Given this list of marker genes AMOT, PTK2B, BCAR1, NOS3, MIR499A, AKT1, SEMA5A (NCBI Gene Id 9037), NFE2L2, FGFR1, PIK3CB, WNT5A, AAMP, ANGPT4, P2RX4, STAT5A, FGF1, MIR146A, SIRT1, EMC10, MIR10A, TMSB4X, MIR150, FGF16, FOXP1, GAB1, ROCK2, EDN1, KDR, TEK, RHOJ, PRKD1, MIR199A1, FGFBP1, PLG, GPI, RIN2, MIR210, MAP2K3, MIR126, ETS1, PRKCA, ANGPT1, GATA3, VEGFC, FUT1, ITGB3, MIR143, JCAD, ANXA1, PLCG1, BSG, GPLD1, ZC3H12A, AGT, MET, ADGRA2, MIR939, NRP2 (neuropilin 2), FGF18, NRP1, MIR10B, MIR27B, MIR342, PDPK1, HDAC9, HMOX1, PRKD2, PLK2, PLPP3, PDCD6, SASH1, TMEM201, PIK3CG, TGFB1, MIR296, SMOC2 (SPARC related modular calcium binding 2), PROX1, ADAM17, LCN2, GRN, SCARB1, CALR, EGF, CD40, CCBE1, FOXC2, MIR21, MIR30A, MIR200A, HIF1A, SPARC, ITGB1BP1, TGFBR3, HSPB1, ATP5F1B, GFUS, FLT4, HMGB1, RAC1, ABL1, GREM1, THBS1, MIR27A, VEGFA, MIR23A, MIR132, MIR1908 (NCBI Gene Id 100302263), AKT3 (NCBI Gene Id 26068), CIB1, ATP5F1A, MIRLET7F1, PTGS2, PIK3C2A (phosphatidylinositol-4-phosphate 3-kinase catalytic subunit type 2 alpha), PIK3CD, BCAS3, ZNF580 (zinc finger protein 580), PDGFB, ATOH8, RHOB, SRPX2, LGMN, MAPK14, WNT7A, HDAC7, MIR31, MIR221, MIR101-1, MIR29A, MIR135B (NCBI Gene Id 442891), RRAS, MIR487B, SP1, GATA2 (GATA binding protein 2), ANXA3, FGF2, CRIPTO (NCBI Gene Id 6997), NUS1, here is a description of the gene set: Human Gene Set: GOBP_POSITIVE_REGULATION_OF_ENDOTHELIAL_CELL_MIGRATION Any process that increases the rate, frequency, or extent of the orderly movement of an endothelial cell into the extracellular matrix to form an endothelium. studied in species Homo sapiens